Given this list of marker genes Il10, Mcl1, Mmp2, Park7, Fzd1, Prkn, Fbxo7, Pycr1, Daxx, Parp1, Map3k5, Prodh, Wnt1, Nono, Ctnnb1, Fbxw7, Atf4, Hif1a, Fgf2, Pink1, Trem2, Adcy10, here is a description of the gene set: studied in species Mus musculus Mouse Gene Set: GOBP_NEURON_INTRINSIC_APOPTOTIC_SIGNALING_PATHWAY_IN_RESPONSE_TO_OXIDATIVE_STRESS The series of molecular signals in which an intracellular signal is conveyed to trigger the apoptotic death of a neuron. The pathway is induced in response to oxidative stress, a state often resulting from exposure to high levels of reactive oxygen species, and ends when the execution phase of apoptosis is triggered.